The following is a description of a gene set: studied in species Homo sapiens Human Gene Set: HP_ABNORMALITY_OF_SKIN_PIGMENTATION Abnormality of skin pigmentation An abnormality of the pigmentation of the skin., and this is the list of marker genes: GJA1, SLCO1B3, TNFSF15, DST, MSH6, SLC24A5, MT-ND5, PMS2, ARL6IP6, GATA1, RECQL4, PALB2, SNAI2, UBE3A, TYR, BTK, GJB6, MT-TF (NCBI Gene Id 4558), CDKN2B, TP53RK, AP3B1, CRIPT, MKRN3, DCT, BLM, ERF, PARN, ERCC8, IRF4, ANTXR2, TERC, MAN1B1, SMARCAD1, SOS2, RRAS, USB1, APC2, LIG4, PAH, IRF1, NPAP1, PAX3, EED, LIPE, C1S, SLX4, HPS3, HEPACAM, IGF2, KIT, KRT5, KIAA0319L, DSTYK, CACNA1F, SMO, HLA-DRB1, SEC23B, THPO, PLXND1, TRIP13, KITLG, DTNBP1, SALL4, SLC9A1, CLCN7, ZMPSTE24, CTC1, IFNG, PANK2, NCF4, PCSK1, CDKN2C (NCBI Gene Id 654235), SPINK5, TWIST2, MAPK1, CPOX, PLEC, LIFR, MEN1, CCR6, NFKB2 (NCBI Gene Id 4791), EDN3, MC1R, MMP2, TNFRSF1B, MPL, KRAS, MMEL1, MAP2K1, CDKN2A, RREB1, CTLA4, CTNS, DUOX2, SMARCA2, CDK4, FANCD2, CBS, XPC (NCBI Gene Id 7508), NR3C1, ATP6V1B2, CBL, BRCA2, TP53, ALK, LAMTOR2 (late endosomal/lysosomal adaptor, MAPK and MTOR activator 2), NSD1, GJB3, GMPPA, RRAS2, CXCR4, RET, PIGA, RNF113A, PPOX, KAT6A, SUZ12, GALC, SLC35A2, ATP2A2, LEMD3, UBR1, DCPS, POGLUT1, KDSR, SDHB, HSD3B2, COPB1, MT-CO1, VPS13B (NCBI Gene Id 54990), RFX7, KANSL1, RPS27, AP3D1, NFIX, TERT (telomerase reverse transcriptase), PRKAR1A, IDUA, CTSC, KDM6B, CASR, PSENEN, AARS1, TMC8, AIP, CAT, DKC1, KNSTRN, SRD5A3 (steroid 5 alpha-reductase 3), TFE3, MLH1, SEC23A, TOP3A, FANCC, HMGA2, BRAF, RAF1, SPRED1, PIK3CD, PROS1, DNAJC21, CREBBP, ALDH3A2, NNT, ADAR, KDF1, ESCO2, SPRED2, MT-TQ, RERE (arginine-glutamic acid dipeptide repeats), BLOC1S6, IRF5, WDR11, ATRX, SMG8, CYBB, POGZ, ANAPC1, SDHC, UVSSA, LAMC2, MT-TH, IKBKG, ABCD1, MAFB, SOS1, TBX1, CDKN1B, RAB27A, SDHD, PWAR1, RIT1, GBA1, EMC1, OCA2, SLC40A1, MSH2 (mutS homolog 2), CYBA, CDKN1C, NOD2, TSC1, IL6, WASF1, MRAP, B4GALT7, WDR45, IGF1, MT-CO2 (mitochondrially encoded cytochrome c oxidase II), CSTA, TCF4, KCNH1, SET, COL7A1, PCGF2, PDGFRB (NCBI Gene Id 5159), CCN2, HPS5, SNRPN, PROC, PTPN22, FKBP10, MC2R, KLHL24, GNAS, AKT1 (AKT serine/threonine kinase 1), TYRP1, MAP2K2, FOXD3, TNFRSF11B, POFUT1, ZNF699, KLLN, FGFR3, GPR101, GNPTAB, TSC2, CYP11A1, TRAF6, GTF2E2, UBE2A, FLNA, DNASE1L3, LYST, WBP11, MT-TL1, SLC27A4, FAS, KMT2D, TINF2, HPS1, FANCL, TYMS, RFWD3, HGD, GTF2H5, PIK3CA, TNPO3, HERC2, NDUFB11, ATP7A, SDHA (succinate dehydrogenase complex flavoprotein subunit A), NOTCH3, XRCC2, PTEN, SPTBN1, CTNNBL1, AEBP1, SNORD115-1, TUBGCP6, SLCO1B1, CARS1, APC, SOX10, NF2, COMT, TUBB, ATM, GNA11, JAK3, SH3PXD2B, MED12, TRPM1, IL12RB1, ANKLE2, GP1BB, FANCG, SLF2 (SMC5-SMC6 complex localization factor 2), BUB1, NOP10, LRBA, CHD8, BRIP1, HBB, NDN, HR, NHP2, FANCI, SKIC2 (NCBI Gene Id 6499), ZEB2, NBN, UBE2T, FANCB, CDKN1A, LTV1, SNORD116-1, CEP57, FBN1, BAP1, GPR143, TOMM7, LAMA3, MLPH, MAD2L2, CAPRIN1, USF3, UROS, AIRE (NCBI Gene Id 326), BLOC1S3, CD28, PLCG2, CDH3, ACTB, PDE4D, INSR, RTEL1, MPV17, COL17A1, LZTR1, TMC6, CWC27, PLAG1, BLOC1S5 (NCBI Gene Id 63915), ZFX (NCBI Gene Id 7543), TP63, ANTXR1, RBM28, FERMT1, PCNT (NCBI Gene Id 9346), EDARADD, HFE, EPG5, TRAPPC11, PTCH2, TFR2, DHX30, CYP11B1, PAX6, TXNRD2, ZPR1, MGMT (NCBI Gene Id 4255), TARS1, SVBP, TMEM127, KDM6A, KCNN3, PORCN, CLTRN, POLA1, BUB1B, PDGFRA, MAPRE2, HPS6, ITGB4, CDH23, PIDD1, ERCC1, RASA2, MT-TW, ALG3, SLC6A19, HJV, IL7, FANCF, MT-ND1, USP8, HPS4, PTCH1, ERCC5, EBP (EBP cholestenol delta-isomerase), HAMP (hepcidin antimicrobial peptide), NR0B1, CHRNA7, WDR73, TERF2IP, BANF1, PSMB8 (proteasome 20S subunit beta 8), HCCS, EDA, DDB2, PIGN, MYO5A, USP48, GNB2, UBAP2L, C1R, COL3A1, COX7B, MRAS, MPLKIP, KIF15, GPNMB, UROD (uroporphyrinogen decarboxylase), CAV1, MAX, LAMB3, EDNRB, ADH5, NPM1, TOE1, POLH, ABCC9, MT-ND6, SMS (NCBI Gene Id 6735), RAD51, MCM4, POMC, IL12A, DDX3X, FANCM, ABCB6, VHL, RBBP8 (NCBI Gene Id 5932), XPA, SLC29A3, BMP6, SIM1, ARVCF, BMP2, ATP10A, PWRN1, ACD, TGM5, STK11, SGPL1, RAD51C, AAAS (aladin WD repeat nucleoporin), STAR, EZH2, TAF4, SOX5, CBLB, KRT14, HPGD, NCF1, DDX11, STEAP3, OCRL, BPTF, ROR2, ALAS2, CARD14, ERCC3, EP300, BTNL2, ST3GAL5, TRAC, WRAP53, LMNA, TNFRSF11A, POU2AF1, SHOC2, NCF2, SEC24C, MITF, BUB3, MT-ND4, TNFRSF1A, SPIB, POT1, CHN1, PDE11A, SASH1, CYBC1, SLC17A5, HIRA, CIB1, APOE, GJB4, JMJD1C, USP9X, KDM5C, MTOR, SUFU, BRCA1, MT-CO3, ERCC4, MAGEL2, SKIC3 (NCBI Gene Id 9652), RPA1, NF1, NSUN2, H4C5, ERCC2, LRMDA, GNAQ (G protein subunit alpha q), REV3L, LBR, DPP9, MT-TS2, FGFR2 (NCBI Gene Id 2263), PSAP, POLE, PTPN11, DCLRE1C, NLRP1 (NCBI Gene Id 82286), HRAS, ACP5, SLC45A2, SMARCAL1, UFD1, PHIP, NRAS (NRAS proto-oncogene, GTPase), PPP1CB, FGFR1, FANCE, FANCA, SOX18, EDAR, ERCC6